Given this list of marker genes Emb, Bsg, Slc16a8, Slc16a7, Slc16a1, Slc16a3, here is a description of the gene set: Proton-coupled monocarboxylate transport Mouse Gene Set: REACTOME_PROTON_COUPLED_MONOCARBOXYLATE_TRANSPORT species: Mus musculus